Given this list of marker genes Gt(ROSA)26Sor, Cyp27a1, Sh3bp5l, Prr19, Gtf2a1, Rnpep, Agpat1, Yars2, Snora74a, Ccdc124, Snhg9, H3c7, Pdgfa, Urgcp, Topors, 1810062O18Rik, Gadd45a, Gm22357, Srsf7, Eci1, Slc25a39, Vdac1, Rab35, Gm26901, Stx12, B230369F24Rik, Macir, Trim17, Sap30l, Tmem208, Fyn, Mir8120, Nanog, Bscl2, Srsf3, Ier2, Gm20544, L1td1 (LINE-1 type transposase domain containing 1), Ccdc17, Cflar, Rpl12, Esrrb, Cdc20, Ncoa7, Sall4, Mkks, Lasp1, Zfp42, Rmnd5b, Fam219b, Gm23201, Apol7d (NCBI Gene Id 100046551), 3010003L21Rik, Rplp0, Ttc21b, Pnrc2, Sigmar1, Gm2093, Bag1, Tmem245, Mir707, H2ac10 (NCBI Gene Id 319173), Trib3, T2, Nr1h3, P2ry6, Tbl1xr1, Snhg5, Psmb5, Prickle1, H2ac5-ps, Kras, Sec24b, 2700099C18Rik, Wdr90, Ap5s1, Adrb2, H2ac13, Pradc1, Mir150, Mapk6, Mcmbp (minichromosome maintenance complex binding protein), Emg1, Dimt1, Gm32950, Rnu7, Gm15706, Got2, Mir219c, Alpl, H1f1, Ncoa5, Mark3, Flywch1, Gsk3a, Tuba1b, Cyb5d1 (NCBI Gene Id 432544), 4930404I05Rik, Snord45c, Gm43403, Gm26802, Setd5, Gsto1, Ptpn3, Ctbp2, Arl4d, Dnph1, Cic, Zfp810, Gm26562, Snord68, Mapk1ip1, Trdmt1, Ilf2, Morf4l1, Gas5, Atf7ip, 2810408A11Rik, Rwdd1, 4933440N22Rik, Nufip2, Ninj1, Apoe, Btg2, 2500002B13Rik, Rnf4, Dapp1, Ptpn6, Cited2, Rimkla, Ifrd1, Slc39a6, Smarcc2, Kit, 1700019D03Rik, Rab26os, Rsad1, Mylpf, Bbof1, Phtf1, Mir18b, Hoga1, 1700027A07Rik, Sulf2, Caml, Mpzl1, Mir6935, Arf3, Hnrnpf, Itpk1, Wiz, Syt7, Trim68, Mettl26, Ddit4, Mir19b-2, Snhg7os, Dpf1, Slc7a5, Gm15441, Igsf9, Gm40332, 1700023H06Rik, Arhgap26, 1700065D16Rik, Bcat2, Nlk, 1810009A15Rik, R3hcc1 (NCBI Gene Id 71843), Haspin, Nfatc4, Cul4a, Igkj5, Ecpas, Fbxo38, Mir3078, Trip4, Ets1, Ilvbl, Baiap2, Snord65 (small nucleolar RNA, C/D box 65), Commd6, Rnf213, Pigbos1, Cfap20, Kmt2d, Gnas, Mdk, Snora81, Mtmr10, Naa60, Pml, Tmtc2, Mamstr, Hnrnpa1, Ahctf1, Aebp2, Rps23rg1, Map3k12, 4632427E13Rik, Gm22744, Erh, Ppa2 (pyrophosphatase (inorganic) 2), Ddx25, Ppp1r10, Plekhm1, Gm26708, Ak3, Eif5a2, Snord43, Neat1, Rab26, Mybl2, Cc2d1a, Thap2, Foxr2, Gm22711, Lrp5, Rps19, Ncl, Hnrnpl, Hnrnpa2b1, Matcap2, Mir8109, Gpx1, H2ac18, Dnajc7, Zfp609, Zmiz1 (zinc finger, MIZ-type containing 1), Naa38 (NCBI Gene Id 78304), Rps20, Brd2, Mtf2, Josd1, Ccng1, Snord2, Rbpms, Crat, Cldn4, H3c4 (H3 clustered histone 4), Gpc2, Frg2f1, Amotl2 (NCBI Gene Id 97534), Moap1, Mreg, Stk31, Prepl, Vps35l, Mir301b, Gm23130, Ndufs1, Thra, Sun2, Zw10, Eri3, Gm23143, Lbr, Dars2, Mkrn1, Rps6ka1, Mir92-2, Arid1a, Ctnna3, Pld2, Khdc4, Grcc10, Rnf5, Ddhd2, Anapc10, Gm8000, Ubb (NCBI Gene Id 22187), H2bc8, Zfas1, Ppp4r3b, Ipo8, Sirt1, 4732491K20Rik, Pms1 (NCBI Gene Id 227099), Gm24201, Usp7, Ctdsp1, Vti1a, Aph1b, C230096K16Rik, Actb, Gm26330, Mei1, Kdm7a, Ipo7, Rnu11, 4930461G14Rik, Poglut1, Fpgs, Kif5b, H3c6, Snord104, Tsn, Tmem42, Mup6, Snord3a, Tmem222, Tecpr1, Mcm3, Tex14, Snora73b, Kpnb1, Ccdc174, Kansl3, Pts, Ik, 1700064H15Rik, Mllt1, Cep350, Snhg3, Aldoa, Rara, Fbxo6, Arih2, H4c11, Rprd2, Tmem39a, Aloxe3, Gclc, Ndufb10, Epop, H3f4, Tead1, Gnaz, Cradd, Dennd10, Rnf187, 2410006H16Rik (RIKEN cDNA 2410006H16 gene), Zfp524, Mettl4, Wapl, 6330562C20Rik, Jarid2, Slc2a3, Creld2, Ccdc167, Chtop (NCBI Gene Id 97092), Gm16253, Fra10ac1, Wdr25, Fam174a, Anks3, Gm7008, Gm29417, Wdr75, Pnrc1, Ndufs7, Plcxd1, BC051226, Gm22422, Nanos1, Marchf8, H4c1, 1700041G16Rik, Snora78, Ddx39b, Rsrp1, Slc25a34, Usp3, Snord60, Nars1 (NCBI Gene Id 98111), Snora44, Atp5mg, Ptpn23, Rps28, Fignl1, Ttc14, Rpl23, Adgrl1, Gm26654, Prdm10, Lmln, Tomm40l, C530005A16Rik, Bcar3, Uqcc3, Abca3, Zfp553, Mettl5, Pigm, Mmadhc, Ier5l, Sf3b3, Klf9, Rbpj, Rps6, Osbpl11, Snora16a, Angel2, H4c8, Spg11, Klf5, Micu2, Txndc15, Mir290a, Cenpl, Mir363, Gne, Sema4b, Ikbkg, Mob1a, Mir8114, Slc2a1, Mir1938, Klf2, Dlc1, En2 (NCBI Gene Id 13799), Gpaa1, Gm15217, Cxxc1, Snhg6, Calr, Trim44, Scarb2, Rtraf-ps, Dvl3, Rgs10, Chac1, Sde2 (SDE2 telomere maintenance homolog (S. pombe)), Utf1, H1f10, Ppp1r15a, Slc15a4, Psat1, Slc27a4, A930004D18Rik (NCBI Gene Id 99212), Ndufa7, Snord12, Ndel1, Gsn, Clhc1, Gm16576, Sumf2, Ankrd55, Eapp, Ddx17, Daxx, Rab5b, Cebpzos, Mir292, Znhit2, Hsp90b1, Otub2, B3galt4, Ppl, Trh, Zc3h10, Gm26444, Asb7, Akt1, Pnpla6, Spred2, Recql, Cers2, Ttc39d, Ndufa13, Ppp4r3a, Ndufaf4 (NADH:ubiquinone oxidoreductase complex assembly factor 4), Cln3, Mir293, Wwp1, Tcf4, Mgat2, Rps27a, Slc33a1, Upp1, Npm1, H4c6, Igsf8, Atl3, Ormdl1, Rpsa, Ncdn, Hsp90aa1, Rnf44, Amd1, Hormad1, Fgfr2, H2bc12, Carmil1, Pdss1, Ppia, Hotairm1, Rpl5, Tsc22d1, Rcc2, Rft1, Malat1, Epc1, BC002059, Evi5, H1f3, Exoc7, Zfp866, Stpg1, Ulk2, H3c15, Knstrn (NCBI Gene Id 67853), Dync2i2, Tpi1, Hsp90ab1, Rnf125, Fv1, Aqp3, Snhg8, C430039J16Rik, H1f2, BC005537, Fmc1, Spry4, Hdac2, Hmga1, Sapcd2, Etnk1, Ankef1, Eif4a1, Cnnm1, Cripto, Arhgef12, Gm29642, Mrps18b, H4c14, Tubb5, Fam171b, Senp6, Mcu, Snora61 (NCBI Gene Id 100217440), Snord78, Ap3d1, Cox20, Mir292b, Gm24452, Cnih4, Mettl5os, Snora73a, Lbhd1, Gcdh, Ccdc107, Ccnl1, Lipe, Sacm1l, Rrn3, Impdh1, Hspa8, Plod1, Nif3l1, Lactb2, H3c2, Klf3, Pus10, Ddx46, Slc25a36, Gm15417, Fau, Drg1, 1110018N20Rik, Med25, Rab30, Ago3, Ppp1r7, Cenpv, Slc16a3, Septin11, Ints6, Med23, Snora65 (NCBI Gene Id 104367), Ccdc115, Fasn, Sp2, Ubald1, Sap30, Cpped1 (calcineurin-like phosphoesterase domain containing 1), Snrpg, Snord49b, Myc, Grk4, H3c8, Sfswap, 2010110E17Rik, H2bc26, Fbxo7, Pdk1, Tbc1d10b, Obi1, Msl2 (MSL complex subunit 2), Ywhaz, Arrdc3, Man1a2, Tlcd2, Xrcc5, Fbxw2, Tmpo, Son, H2bc18, Ccnd1, Foxh1, Rpl13, Tut7, Slc29a1, Rps12, Ssr4, Fiz1, Asph (aspartate-beta-hydroxylase), Dicer1, Dusp9 (dual specificity phosphatase 9), Rcn2, Fam169b, Rarg, Chchd1, Mns1, Snord118, Rab40c, Bola3, Yipf2, Ppp1r13l, Fam3a, Cygb, Znrf1, Arhgap25, Daglb, Mrpl52, H4c2, Agfg1, Mir5136, Hmces, Syce1, 4632404H12Rik, H2ac22, Gtf2ird2, Trim71, Dleu2 (deleted in lymphocytic leukemia, 2), Ndufaf3, Mir130b, Set, H2bc21, Zfp57 (zinc finger protein 57), Arc, Ctnnb1, Dhx38, Junb, Tex30, Gtf2b, Rps2, Prmt5, Eprs1 (NCBI Gene Id 96892), Gm13483, Nop14, Pabpc1, Tdrd3, Zfp174, Sirt7, Pigb, Kntc1, Shld1, Ptms, Ptpa, Rpl7, Gm22489, Hsf2bp, Zfp597, Atg9a, Clba1, Ppp1r12b, Ube2l3, Ints10, Nhlrc3, Zdhhc17, Bcl7a, Rps10, Snora21, Eif1, Snora24, Tiparp, Kmt2e, Tfrc, Eps15, Casz1, Tmem106b, Mapk14, 2810029C07Rik, Id2, Usp4, Ntrk2, Ptbp1, Rny3, Gm12063, Dppa5a, Tmem163, Cnpy3, Gm4189, Sub1, Plk3, Srprb, Nsun2, BC031181, Nr0b1, H2az1, Zdhhc6, Ccnf, Zwilch, Usf1, Tardbp (TAR DNA binding protein), Ppil3, Tuba1a, Msantd3, Id1, Piezo1, Mrpl30, Ldb1, Itgav, Cyp1b1, Pex12, Gm40190, Mir1983, Mir191, Olig1, Gm11520, Cul5, Coil, Arl6ip1, Jmjd6, Ywhag, Mir142hg, Dcp1a, Slc25a1, Rps29, Cgref1, Zfp385b, Nsfl1c, H1f5, B4galt3, Uxs1, Tmem191, Srsf2, Pdhb, Trim28, Dazap1, Fcor, Sfxn5, Coq8a, Prpsap1, Cdk5rap2, Triobp, A430105J06Rik, Mir22hg, Tmem107, Lrrc41, Hoxc9, Nudt3, Atad1, Mir290b, Brk1, Lrrc8d, Def6, Lrsam1, Plekhg2, Mycn, Rpl10a, Rcc1l, Klf4, 3110083C13Rik, Uggt1, Cd109, Retreg2, 2210412B16Rik, Agbl5, Sulf1, C130036L24Rik, Srp19, Tmem168, Rps15, Arf2, Slc38a2, Noc3l (NCBI Gene Id 57753), Gm26511, Gm11454 (NCBI Gene Id 100504589), Cmss1, Gbx2, Cct7, Hk2, Casp2, Ubqln4, Tlr4, Parp2 (poly (ADP-ribose) polymerase family, member 2), Cct8, 1700042D02Rik, Tcf15 (transcription factor 15), Mak16, Prmt7, Kbtbd6, Mad1l1, B4gat1, Ap2b1, Tmem243, Fam222a, Polg, Pnpla2, Apba1, Aplp2, Top2b, Rcc1, Cfap298, U2surp, Lmna, Cacna2d4, Pym1, Ddx50, Eif2a, Ltbp1, Traf7, Snord32a, Rrm2, Nkiras1, Olig2, Dmxl1, Rpph1, Klhl21, Igfbp2, Ubtf, Eeig1, Rpl15, Upf3b, 1700113A16Rik, Polr3e, Slmap, H2ac7, Rps24, Hdhd2, Rab13 (NCBI Gene Id 77496), Gm10190, Gm16124 (NCBI Gene Id 102636154), Hnrnpab, Nr1d1, Gm26447, Slc6a16, Mir135b, Rnu12, Dcaf7, Tyms, H3f3a, Becn1, Phf7, Gm1965, Tnrc6c, Sox11 (NCBI Gene Id 67779), Gtf3c6, Glis2, Unc5a, Notch2, Ptprs, Triap1, Themis2, Vamp4, Errfi1, Snora57, Slc25a12, H2bc13, Gm11335, Nrxn1, Cbx7, Scyl3, Etohd2, Atxn7, Eno1, 1700003G18Rik, Phc1, Ccdc88a, Ndc1, Lmtk2, Scarna2, Rplp1, Tex264, Bpnt1, Gm24044, Esco1, Snora64, Rpl36a, Gm10244, Slc16a6, Akap11, Polr2i, Armt1, Srsf1, Ebpl, Ndufv3, Jtb, Gm16201, Impa2, Snord34, Disp1, Mir5121, Ldha, Zfhx2, Gm24616, Rabggtb, Cnpy1, Fam78a, N4bp1, Pfn1, Vpreb1a, Snora33, Map2k6, Mettl2, Gm4285, 4930481B07Rik, Mepce (NCBI Gene Id 27978), P4ha1, Mia2, Rab8a, Hmox1, Gm22973, Micall2, Zfp710, Foxj3, Cmas (NCBI Gene Id 12764), Man2b2, Porcn, Sirt4, H3c1, Gm25541, Cbx3, Zic3, 2610318N02Rik, Cep95, Clcn3, Xpo7, Hoxa1, Pcid2, Scamp1, Rpl4, 4930532G15Rik, Cep131, Rdm1, Glul, Tpk1, Ctcf, Ets2, Plekhg4, Snora26, Rpl28, Cdh1 (NCBI Gene Id 12550), Nuak2, Fcgr3, Gm16046, Sharpin, Jade1, Rmrp, Lemd2, Ublcp1, Ddx43, 5730420D15Rik, Otop1, Nsd1, 4933433G15Rik, Gm13421, Gm14261, Gm13783, Gm20587, Abhd3, Ubc, Vps52, Abcb6, Micos10, Slc35b4, Nr2c2, 4930594M22Rik, Dnaja1, Ormdl3, Klhl26, Kdm2b, Dusp1, Parp1, Nt5c3, Hkdc1, Cenpu, Ddx5, Klf10, Ccdc126, Pafah1b1-ps1, Tedc1, Rpl18a, Crlf3, Dennd6a, 4930563E18Rik, Fbxo15 (F-box protein 15), Tprg1l, Smap1, H2ac12, 5031425E22Rik, Patz1, Rrm1, Edf1, Sox2ot, Ring1, Coa5, Gm28996, Actr3b, Ndufa2, H2ac6, Gm10138, Uba52, Golga5, Etv5, Smad7 (NCBI Gene Id 17131), Kdm2a, 1110038B12Rik, Plekha4, Tgif1, Rpl18, Gpx4, Chmp5, Gm22513, Exosc2, 1700112D23Rik, Atp6v1h, Mrpl49 (mitochondrial ribosomal protein L49), Zfp219, Fn1, Poldip3, Mpc2, Dancr (NCBI Gene Id 70036), Adad2, Zfp672, Dgcr8, Zkscan2, Parp11, Calm1, Yjefn3, Tcf12, Tasor2, Ptma, Nkiras2, H3c10, A230083N12Rik, Agpat4, Hyls1, Lias, Tpgs1, Hipk1, Gm15459, Ap3m2, Chaserr, Znfx1, Rdh10, Tbc1d17, Arhgef1, Anxa11, Egr1, Ddit3, Scd2, Efcab12, Dusp10, Vps26c, Fgf4, Csrnp2, Arl8a (NCBI Gene Id 68724), Wwox (WW domain-containing oxidoreductase), Ube2q1, Wars1, Gm12758, Eif2s2, Tfcp2l1, Ints5, Zfp799, Sfpq, Rpl22l1, Sgf29, Plekha1, Ciapin1, 4931440P22Rik, Gjc1, Txnip, Vangl1, Snord49a, A330023F24Rik, Coq9, Zbbx, Gm25744, Esd, Got1, Alg13, 9130401M01Rik, Sgo2a, 0610009L18Rik, Bap1, H3c11, Plekhg5, Mgme1, BB557941, Ube2d3, Wdr26, Hspe1, Gm11398, 5930411N13Rik, Sh3bp1, Camk2n1, Golt1b, Pask (PAS domain containing serine/threonine kinase), Ivns1abp, Irf4, Insig1, Pwwp2a, Etnk2, Fgf9, Rbm3os, Gm11613, Mrpl1, Rraga, Smad3, Gm22589, Cyb5r1, Rimoc1, Them4, Slc7a6os, Hnrnpr, Tubb3, Maco1, 1700096K18Rik, H2ac25, 2510002D24Rik, Elovl6, Ssr2 (NCBI Gene Id 99800), Gm17484, Txnl4b, Bola1, Socs2, 4930589O11Rik, Fbxl13, Slc12a2, Eaf2, Lrrc8b, Slc39a4, Ep300, Sema6a (sema domain, transmembrane domain (TM), and cytoplasmic domain, (semaphorin) 6A), Atxn2l, Hus1, B230319C09Rik, Nvl, B3gnt7, Prdx6, 4930477E14Rik, Gart, Fbxo31, Gm24016, Gm23639, Mir1949, Fos, H2ac4, Snora17, Wsb2, Nipal3, Tdh, Cmklr2, Abca17, Xrcc3, Rpl36al, Ing1, Tet2, 1600020E01Rik, H2bc11, Knl1 (NCBI Gene Id 76464), Otud4, Mir124a-1, Nde1, 2410002F23Rik, Cisd3, 1810041H14Rik, Polr3gl, H1f4, Mir6936, Slx4ip (SLX4 interacting protein), Camkmt, Mrs2, Slbp, Gm9694, Tpm1, Cltc, Calu, Mir291a, A730013G03Rik, Eef1b2, Idh3g, Actg1, Adgrl2, Snx5, Rrp15, Gpr176, Gm5577, Pcbp1, Gm15860, Cggbp1, Hspa5, Rasd2, Fbxo11, Atoh8, Folr1 (folate receptor alpha), Snord80, H2bc7, Slc20a1, H2ac19, Gm26885, Tle4, Zfp280d, Ankle2 (ankyrin repeat and LEM domain containing 2), H2bc22, Id3, Cdkn1a, Ercc6l2, Tsnax, Zfp882, Immt, Nhsl3, Azin1, H2ac15, Hydin, Sp3, Irf8, Spry2, Usp8, Slc39a9, Fut10, Psmb3, Rasl10a, Fam222b, Ednrb, Ipo11, Pgk1, Mettl3, Ddx19a, Rny1, Prdx1, Appl2 (adaptor protein, phosphotyrosine interaction, PH domain and leucine zipper containing 2), Sinhcaf, Chd2, 1700045H11Rik, H3f3b, Armc10, Zmat3, Slc47a1, Desi2, 4833445I07Rik, Mllt6, Bcl3, Dusp6, Platr22, Rpl41, Alyref2, Tmem183a, Rn7s6, Foxn3, Car14, Mettl23, Utp14b, Foxk2, Pten (NCBI Gene Id 70161), Gm12762, Tet3, Ntn1, Dppa2, Snord55, Zfp36l1, Rb1cc1, Pxmp4, Gpr137, Gm24029, Rab29, Fbf1, 2010001A14Rik, Gpc4, Gm26205, Ankrd37, Hspa4, Gm30238, Rab7, 4930558J18Rik, Cep295, Dynll2, Ndrg3, Mir8105, Tuba4a, Phtf1os, Anp32a, Inhbb, Snord22, Erlec1, Hacd2, Gm13136, Wdr87-ps, Supt5, Ftl1, Cdx1, Rasgrf2, Sgk1, Atosa, Lyset, Tob1, Kdm4c, Mir291b, Pigl, H2bc3 (H2B clustered histone 3), 1110006O24Rik, Fzd3, Rps8, Pus3, Idh1, Snord110, Jmjd1c, A430005L14Rik, Phrf1, Top3b, Tia1, Snord42b, Chd8, Ndufb5, Vegfa, Tbx3, 2410137M14Rik, Eif4a2, Fbxl9, Zfp532 (NCBI Gene Id 328977), Dbp, Eid1, Gm16998, Kmt5a, Kdm5b, Maf1, Fam3c, Sntb2, Kcnab3, Rps9, Rnf126, AU040320, Neurog3, Cry2, Trim6, Mir6236, Ago2, Farsa, Epha2, Oplah, Cdc123, Nfix, C230035I16Rik (NCBI Gene Id 320842), Zfp846, Acp2, Rfx7, Pkp2, Slc7a6, Izumo1, Eif5, Mfsd12 (NCBI Gene Id 73822), 4930539J05Rik, Ech1, Tmem131, H4c4, Rbmxl2, Timm8b, 1700101I11Rik, Wdr4 (WD repeat domain 4), Qki, Calm2 (calmodulin 2), Tsen34, 1700122E12Rik, Mdm2, Igf2bp3, Alg9, Hexim1, Ufl1 (UFM1 specific ligase 1), Rbm33, Rab3a, Ptp4a2, Cops7a, Dedd, Pou5f1, Pate2, Ldlr, Elf1, H4c9, Ankzf1, Cnnm3, Mir193a, Ufsp1, Phf8, Mcl1, Rpl9, Gm16170, Atn1, Zcwpw1, Prkcsh, Stx11, H2bc6, H4c12, Rpl23a, Creld1, H2ax, Man1a (mannosidase 1, alpha), Kat6b, Catsperg1, Cep20, Ttc41, Zfc3h1, Ppp2r2d, H2bc15, Fam169a, Zfp451, Epb41l4aos, Fbxo47, Uqcrh, Tmbim1, Ywhae, Lins1, Mat2a, Gm27042, Cntnap2, Mir20b, Brme1, Snhg12, H2ac21, AI480526, H2ac11, Aqp5, 3110040N11Rik, Tmem160, Swsap1, Ptp4a1, Gm25894, Pde4d, Rps27, Eif4g2, Arid3b, Snord13, Iqcb1, Smim33, Spink10 (serine peptidase inhibitor, Kazal type 10), Altre (NCBI Gene Id 100504026), Klc3, Ssbp2, Glyr1, Bmp4, Smim14, Meiosin, Galnt1, Dus1l, Sf3b1, Gm16876, Tubgcp5, Ksr1, Gm19705, Unc50, Odad3, Sphk2, Cdk13, H2ac20, Gm25789, Mfsd11, Lpin1, Elovl5, H4c18, Snora9, Nfatc2ip, Rpl6, Mir1894 (microRNA 1894), Tpt1, Gpr160, Usp31, BC048644, Odad4, Mapk8, Gm35986, Entpd5, Hsd17b12, Pmaip1, Dagla, Kis2, Prr14 (NCBI Gene Id 260374), Eef1a1, Hes1, Zfp617, Scaf1, Fam217b, Gm25878, 2610005L07Rik, Top1, Aldh18a1, Mymx, Hnrnpu, Sdhd, 1700016H13Rik, Alg12, Mir207, Gm12974, Rpl13a, Tfap2c (transcription factor AP-2, gamma), Tmem214, Rps19bp1, Neurl4, Osbp, Shroom3, Rnf14, Abhd16a, Ccnd2, Snrnp27, Miip, Mrtfa, Rps18, Gm11767, 4732440D04Rik, 5730405O15Rik, Slc39a13, Bmal1, H2ac8, Cd53, Gm22680, Galnt11, Cecr2, Gm10308, Fam193a, Szrd1, Tti2, Tmem205, Lncenc1, 2810405F17Rik, G3bp2, Nup85 (NCBI Gene Id 445007), Rfxap, Eef2, Slc7a7, 1700056E22Rik, Rmnd1, Gm25939, Nemp2, Clic4, Wbp4, Nsmce1, 1700066M21Rik, Gm15969, Enc1, Frmd8os (FERM domain containing 8, opposite strand), Spry1, Gm26224, E230016M11Rik, Lefty2, Zfp786, Gtf3c3, Ube2n, H2ac14-ps, Snhg15 (small nucleolar RNA host gene 15), Nop56, Flad1, Rabep1, Spp1, Gm26631, Slc3a2, Hfm1 (NCBI Gene Id 381663), Rpl3, Zbtb37, 1110004F10Rik, Gtf2ird1, Ubac2, H4c3, Gm15420, Ccdc171, Gm12279, Fzd7, H2bc27, Pcif1, Agap2, Arih1, Golph3l, Ubn1, Bad, Gm15663, Pim1, Msh6, Ssbp4, Sod1, H3c3, Birc3, Mboat7, H2bc4, Gapdh (glyceraldehyde-3-phosphate dehydrogenase), 4930509E16Rik, Tubb4b, Sox2, Gm27017, Gm26608, B130034C11Rik, Proser1, Polr2a, Ccdc159, 4931406C07Rik, Zbtb7b, 6230400D17Rik, Map1lc3b, Rif1, Imp4, Gm13033, Vrtn, Mcoln2, Gm25855, Ankrd40, Stag3, Acp6, Phb2, Gm19426, Ak2, Lratd1, Gm25867, Zc3h6, Gm23246, Dnajb14, Resf1, Oxsr1, Fbxw8, Mitd1, Uba2, Zfp687, Lamtor2, Aspa, Kat7, Map4, Ncor1 (nuclear receptor co-repressor 1), Ly96, Septin4, Acsl3 (acyl-CoA synthetase long-chain family member 3), Sesn2, Txnrd1, Akt1s1, Zfp37 (NCBI Gene Id 22696), Synj1, Ggact, Klhl22, Nudt5, Cdc37, Capzb, Trappc2b, Cnppd1, Rps11, Ctnnal1, Ciart, Tor1a, H3c13, Btf3l4, Etfa, Pex13, Ddx19b, Nabp1, Gls, Map3k4, Zc3h12a, Ssc4d, Snx33, Pura, Cnot8, Dda1, Gid8, Ddx3x (DEAD box helicase 3, X-linked), Sipa1l3, Aarsd1, Arl15, Lnpep, here is a description of the gene set: from publication Yevshin I, Sharipov R, Kolmykov S, Kondrakhin Y, Kolpakov F (PMID 30445619) species: Mus musculus Genes containing one or more binding sites for (Ell2) in their promoter regions (TSS -1000,+100 bp) as identified by GTRD version 20.06 ChIP-seq harmonization. Mouse Gene Set: ELL2_TARGET_GENES